Given this list of marker genes ERG28, ELF2, METTL5, TRIM5, SECISBP2, NANS, MCM7, DARS1, CXorf38 (NCBI Gene Id 159013), NMT2, CD38, EEF1G, THOC5, SLC20A1, PTCD1, AARS1, ARL5B, DHPS, NUP155, ACTR3B (NCBI Gene Id 57180), CCNL1, WDR75, CACNA2D4, SAAL1, CSRP1, SMIM30, ATL2, CITED2, CDV3, RNGTT, MRTO4, CMSS1, EPHX3, LUC7L, PDCD6, NELFB (negative elongation factor complex member B), LCMT2, EYA1, MAK16, RBFA, MCTS1, ST13, QNG1, WDR55, HSPBAP1, TOP1MT (NCBI Gene Id 116447), ZC3H10, COPS5, CNIH2, C19orf53, TMEM179B, ACKR4, MRPL42, AGFG1, ZCWPW2, LYAR, HLA-DRB1, GNPTG, ANKRD28, LTO1, EIF2B4, RNF31, OAT, POLR2F, IFT80, COX10, RCC2, ACKR3, CHKA, HK2, CYP51A1, ESCO1, PSMB9, RNF135, MRPL19, GPR89B, MRPL35, GEMIN7, PRKCA (protein kinase C alpha), SPCS2, GMEB2, DLGAP1, LDAH, SLC1A4, POLR2G, HSPA1B, FAM133B, COPE, BAX, MRPL10, LINC00511, MRPL1, TXNIP, FAM43A, RBM15, PDE4DIP, RBM34, AP3M2, DCT, FGF13, GPR183, UTP3, CORO1C, NRBF2, RNF4, GIMAP6, EIF3J, FBXL3, CYP2W1, PDP1, EIF2B1, UBE3D, CA7, SNAPC3, PCYT2, PDLIM5, PEX3, NBN, PSMB10, PUM3, PYCARD, GOLGA7, XRCC6, GPER1, FAAP100, PLPPR3, KIN, MFSD1, MRPL16, ARHGAP11A, PPIP5K1, SLC35B3, NTAQ1, CSGALNACT2, AGBL5, COA5, CCDC51, TCTA, MRPL11, CD320, SLC39A9, PCLO, MTUS2, GTPBP4, TWSG1, TIMM10, WASHC4, PRKDC, ING5, FAM174C, EXOC2, MAFK, MRPL33, XRN2, DDX31, GPATCH2, TPI1, RIOK1, PRODH, DAPK3, NEDD8, TMEM222, DNAJA1, TIMM21, UBA5, CALU, METTL2B, APRT, COX17, REXO2, PLK3, RANBP1, GADD45A, NUDT2, SLC45A4 (NCBI Gene Id 57210), ZBTB8OS, CNKSR3, OTOS, UTP14A, COMMD2, SRI, ARL4A, TLR2, RABEPK, LAS1L, KLRK1, FGF23, MIS12, STT3B, DCTD, TK2, GCSH, NQO2, MOSMO, NKIRAS1, MON1B, SHMT2, QTRT1, RLIG1, NABP1, here is a description of the gene set: Genes down-regulated in the activated CD4 T cells (48h): control versus interferon alpha. The aim of this study was to identify genes regulated by IL-12, IL-18 and IFN-alpha during early differentiation of human Th1 cells species: Homo sapiens from publication Filén S, Ylikoski E, Tripathi S, West A, Björkman M, Nyström J, Ahlfors H, Coffey E, Rao KV, Rasool O, Lahesmaa R (PMID 20304822) Human Gene Set: GSE20198_UNTREATED_VS_IFNA_TREATED_ACT_CD4_TCELL_DN